The following is a description of a gene set: Human Gene Set: GOMF_STORE_OPERATED_CALCIUM_CHANNEL_ACTIVITY studied in species Homo sapiens A ligand-gated ion channel activity which transports calcium in response to emptying of intracellular calcium stores., and this is the list of marker genes: TRPC6, STIM2, TRPC5, TRPC7, TRPC4, ORAI1, ORAI2 (ORAI calcium release-activated calcium modulator 2), TRPC3, ORAI3, TRPC1